Given this list of marker genes TNNT2, EFEMP2, ISL1, PROX1, COL11A1, BMP4, TPM1, ANKRD1 (ankyrin repeat domain 1), NAGLU, TGFBR1, MYH6 (NCBI Gene Id 4624), EGLN1, DLL4, CNTF, BMP10, NRG1 (neuregulin 1), SERP1, SMAD4, TNNI1 (troponin I1, slow skeletal type), SMAD7, MYF6, LRP2, TBX1, ADARB1, FZD2, FOXH1, MYF5, LIF, MIR143, ARID5B, FOXC1, NKX2-5, ZFPM2, TCF15, WNT2, PAX7, RYR2, COL3A1, TGFB1, TBX20, MYH7, TTN, MYL2, ENG, MYL11, POU4F1, MIR195, HEY2, PTCD2, PITX2, SMTNL1, S1PR1, BMP2, HEG1, VANGL2, MYL3 (NCBI Gene Id 4634), FOXC2, FZD1, TGFBR3, ACTC1, TNNI3, GMPPA, XIRP2, SHOX2, NOTCH1, BMPR1A, CHD7, ZFPM1, MYLK2, DSP, FKBP1A, TNNC1, MYBPC3, GSC, FGFR2, NOG, HAND1, MYLK, PKP2, UBE4B, TGFB2, EDNRA, RBPJ, TCAP (titin-cap), MED1, MIR145 (NCBI Gene Id 406937), here is a description of the gene set: studied in species Homo sapiens The process in which the anatomical structures of muscle are generated and organized. Human Gene Set: GOBP_MUSCLE_ORGAN_MORPHOGENESIS